The following is a description of a gene set: Mouse Gene Set: GOBP_REGULATION_OF_DNA_BINDING studied in species Mus musculus Any process that modulates the frequency, rate or extent of DNA binding. DNA binding is any process in which a gene product interacts selectively with DNA (deoxyribonucleic acid)., and this is the list of marker genes: Smo, Fbxw7, Hipk1, Psen1, Mdfi, Zc4h2, Wfikkn1, Jak2, Trim28, Id1, Zfp462, Dot1l, Mad2l2, Foxc1, Pax6, Traf3ip1, Hipk3 (NCBI Gene Id 15259), Irf4, Ifi213, Tfap4, Trim6, Lef1, Msx1, Zbtb7a, Nek2, Hipk2, Smarca4, Ager, Twist1, Pou4f1, Nfib, Mmp9 (NCBI Gene Id 99431), Ngf, Jun, Ddrgk1, Rb1, Ifng, Pitx2, Park7, Egf, Sumo3, Zfp90, Tnks, Tgfb1, Prkn, Ifi214, Calm1, Edf1, Igf1, Hcfc2, Hes1, Lif, Hand1, Wfikkn2, Rsf1, Twist2, Myocd, Lhx2, Ifi206, E2f1, Pou4f2, Ilrun, Habp4, Hmgb1, Ifi203-ps (interferon activated gene 203, pseudogene), Isl1, Msx2 (msh homeobox 2), Brd4, H1f0, Mndal, Taf10, Nme1, Pax7, Nsd1, Ifi208, Gata3 (GATA binding protein 3), Zmpste24 (zinc metallopeptidase, STE24), Hey2, Ifi207, Hmga2, Sox11, Hmgb2, Hand2, Zbtb7c, Dazap2, Ercc2, Ifi203, Cpne1, Rnf220, Hjurp, Gzma, Txn1, Ski, Ctnnbip1, Gata1, Ifi209, Id2, Pinx1, Sumo1, Runx1t1, Lamtor5, Mir744, Plaur, Niban2, Sirt2, Sp100, Neurod1, Traf6